The following is a description of a gene set: studied in species Homo sapiens Any process that stops, prevents, or reduces the frequency, rate or extent of the regulated release of a gonadotropin. Human Gene Set: GOBP_NEGATIVE_REGULATION_OF_GONADOTROPIN_SECRETION, and this is the list of marker genes: INHBA, INHA, GJA1, OPRK1, CRH, NPVF, INHBB, TACR2